The following is a description of a gene set: species: Homo sapiens Any process that modulates the frequency, rate or extent of cell communication via electrical coupling. Cell communication via electrical coupling is the process that mediates signaling interactions between one cell and another cell by transfer of current between their adjacent cytoplasms via intercellular protein channels. Human Gene Set: GOBP_REGULATION_OF_CELL_COMMUNICATION_BY_ELECTRICAL_COUPLING, and this is the list of marker genes: ASPH, TRDN, HRC, CAMK2D, TBX5, PDE4D, GJD3, CALM1, CASQ2, SRI, IRX3, CALM2, SLC8A1, CAV1, GJA5, CALM3, ANK3